Given this list of marker genes Gemin5, Rbmx, Rbm24, Snrpn, U2af1, Rsrp1, Srsf6, Ppil3, Sf3b5, Rbm41, Slc38a2, Cwc15, Srrm1 (serine/arginine repetitive matrix 1), Cdk12, Hnrnpu, Paxbp1, Rbm48, Kat2b, Cdc5l (NCBI Gene Id 71702), Cdc5lrt9, Srpk1, Fam50a, Prpf6, Rbmx2, Usp39, Supt6, Upf1, Cript, Atxn7l3 (NCBI Gene Id 217218), Raly, Smn1, Sugp2, Phf5a, Esrp1, Hnrnpl, Rbmxl1, Cwc22rt3, Thoc5, Coil, Ubl5, Tdrd6, Ddx39b, Prpf4b, Ppp1r8, Supt7l, Armc7, Rest, Hnrnpf, Tcerg1, Srsf7, Ddx47, Rbm44, Rbm25, Larp7, Cwc22rt4, Tsen34, Hnrnph3, Cdc40, Celf4, Clasrp, Snrpd1, Nova2 (NCBI Gene Id 434131), Hnrnpul1, Cirbp, Snrnp200, Plrg1, Rbm17, Crnkl1, Ppie, Rbm14 (RNA binding motif protein 14), Ivns1abp, Pqbp1, Lsm1, Cwc22, Zfp638, Ecd, Nup98, Mfap1b, Srsf8, Eny2 (ENY2 transcription and export complex 2 subunit), Hnrnpa1, Sf3b2, Hnrnpc, Snrnp40, Taf6l, Dhx16, Srrm2, Dcps, Pcbp4, Clp1, Wbp11, Hnrnph1, Setx, Dhx9, Ddx1, Celf5, Wt1, Rbm8a2, Psip1, Mettl16, Rbm8a, Prpf39, Trrap, Rpusd4, Prpf8, Dhx15, Taf9, Prpf31, Eftud2, Rnu2-10, Cwc22rt6, Celf3, Polr2a, Ptbp3 (NCBI Gene Id 99962), Pus1, Thumpd2, Ddx46 (DEAD box helicase 46), Clk1, Cwc22rt7, Cdc5lrt6 (cell division cycle 5 like, retrotransposed 6), Thoc2, Zranb2, Tia1, Trpt1, Rp9, Acin1, Mettl4, Bcas2, Rbm12, Prkrip1, Hnrnpll, Lsm6, Rbmy, Htatsf1, Cdc5lrt5, Gemin6-ps, Ildr2, Prdx6b, Mettl14, Snw1, Zfp326, Myod1, Son, Celf1, Syf2, Clk3, Dazap1, Rbm22, Scnm1, Tada3, Zbtb8os, Hnrnpa2b1, Rbfox3, Snrpd2, Clk4 (CDC like kinase 4), Snrpd3, Ppil2, Tra2b, U2af2 (U2 small nuclear ribonucleoprotein auxiliary factor (U2AF) 2), Prpf4, Nono, Srpk3, Arglu1, Cwf19l1, Rbpms2, Ern1, Scaf11, Supt20, Prpf19, Rbmyf6, Wtap, Txnl4b, Ubl5b, Snip1, Wbp4, Ptbp1, Ahnak2, Alyref, Snrnp70, Usp4, Rbpms (RNA binding protein gene with multiple splicing), Rbm15, Ddx42, Jmjd6, Mtrex, Rsrc1, Sf1, Rnu11, Hnrnpa3, Ppwd1, Isy1, Srek1, Rbm7, Ddx17, Lgals3, Iws1, Cdc5lrt1, Prpf38a (PRP38 pre-mRNA processing factor 38 (yeast) domain containing A), Ncbp2, Rbm12b2, Snrnp25, Rbm5 (RNA binding motif protein 5), Thoc3, Rnps1, Syncrip, Hnrnpul2, Zfp64, Luc7l2, Ddx39a, Ccar2, Zc3h10, Dhx8, Khdrbs3, Arb2a, Taf15, Fbxo24, Lsm4, Hnrnpm, Zfp830, Wdr77, Mbnl3, Clns1a, Magoh, Mettl3, Rbm38, Rbmyf3, Snrpert, Ncbp1, Usp22, Sap18b, Ddx20, Rtraf, Ddx41, Akr1c6, Ints15, Akap17b, Akt2, Sf3a2, Zc3h13, Yju2, Tsen15, Arl6ip4, Rbmyf1, Srsf4, Frg1, Ildr1, Rps26, Gemin8, Srsf1, Prpf40a, Sgf29, Lsm10, Nrde2, Lsm7, Mbnl1, Casc3, Tada1, Thoc7 (NCBI Gene Id 66231), Cdk11b, Cwc22rt2, Sart1 (NCBI Gene Id 20227), Eif1, Sfswap, Cd2bp2, Ccnl1 (cyclin L1), Srsf2, Strap, Nsrp1, Pnn, Fra10ac1, Celf6, Cwc25, Gpkow, Luc7l3, Gm7324, Hnrnph2, Srsf5, Lsm2, Srsf9, Sf3b4, Snrpg, Snrpa1, Ddx5, Rbm39, Rrp1b, Celf2, Thrap3, Grsf1, Prpf38b, Cwc22rt1, Eif4a3, Lsm8, Zrsr2, Larp7-ps, Hnrnpk, Rbmyf9, Rbm6, Taf10, Rnf113a2, Ilf3, Slu7, Khsrp, Dyrk1a, Smu1, Ppp4r2, Khdc4, Rbm15b, Ik, Cactin, Srpk2, Snrpc, Puf60, Zpr1, Sf3a1, Ttf2, Usp49, Rbm12b1, Clk2, Scaf1, Rbm20, Alyref2, Qki, Eif4a3l1, Ddx23, Srsf3, Snrnp48, Ahnak, Sap18, Gpatch8, Cdc5lrt7 (cell division cycle 5 like, retrotransposed 7), Zc3h14, Ybx1, Srsf12, Rbm4, Hmx2, Dhx38, Zbtb7a, Mbnl2, Yju2b, Sart3, Rnf113a1, Esrp2, Aff2, Rbm3, Smndc1, Dnajc17, Cdc5lrt4, Sfpq, Snrpf, Usb1 (NCBI Gene Id 101985), Elavl4, Hspa8, Rbm28, Prdx6, Ppih, Fastk, Sf3a3, Rbm11, Ppil1, Umod, Ess2, Tsen54, Rbm42, Mfap1a, Upf3a, Xab2, Khdrbs1 (NCBI Gene Id 20218), Kat2a, Pus7, Taf5l, Tardbp, Exosc10, Sugp1, Prpf18, Slirp, Prx, Lmntd2, Tmbim6, Zmat2, Upf3b, Prpf40b, Sf3b1, Gcfc2 (NCBI Gene Id 330362), Magohb, Gemin2, Rtcb, Habp4, U2af1l4 (NCBI Gene Id 233073), Gemin4, Rbm47, Rnu12, Slc39a5, Taf12, Prmt1, Rbfox1, Aar2, Lsm5, Aqr, Npm1, Ccnl2, Cwc22rt5, Arvcf, Nova1, Snu13, Ptbp2, Dhx40, Brdt, Lsm3, Dbr1, Cdc5lrt8, Zmat5, Obi1, Khdrbs2, Cdc5lrt10, Thoc1, Fus, Snrpb2, Prmt5, Txnl4a, Rbmxl2, Virma, Thoc6, Snrpb (NCBI Gene Id 99190), Cenatac, C1qbp, Nol3, Prpf3, Tfip11, Eif4a3l2, Snrpa, Prmt7, Sf3b3, Rbm4b, Zcrb1, Srek1ip1, Malat1, Snrnp27, Rbfox2, Gemin6, BC005624, Ctnnbl1, Rnpc3, Pik3r1, Luc7l (NCBI Gene Id 72300), Cwf19l2, Zcchc8, Wdr83, Sf3b6 (NCBI Gene Id 77722), Tra2a, Cdk13, Rps13, Srsf10, Snrpe, Fmr1 (fragile X messenger ribonucleoprotein 1), Srrm4, Atxn7, Pdcd7, Ythdc1 (YTH domain containing 1), Sde2, Cir1, Bud31, Bud13, Gemin7, Pabpc1, Rbm10, Ncl, Tssc4, Tsen2, Snrnp35, here is a description of the gene set: species: Mus musculus The process of removing sections of the primary RNA transcript to remove sequences not present in the mature form of the RNA and joining the remaining sections to form the mature form of the RNA. Mouse Gene Set: GOBP_RNA_SPLICING